The following is a description of a gene set: Mouse Gene Set: REACTOME_DNA_DOUBLE_STRAND_BREAK_REPAIR species: Mus musculus DNA Double-Strand Break Repair, and this is the list of marker genes: Pold1, Rnf4, Nsd2, Rmi2 (NCBI Gene Id 436337), Kpna2, Rfc5, Brip1, Lig4, Kdm4b, Top3a, H4c2, Babam1, Polq, Herc2, Brcc3, Eya1, Firrm, H2bc9, Lig3, Rad51b, Spidr, H2bc14, Rpa1, Xrcc4, Sirt6, Smarca5, Wrn, Hus1, Rad1, Xrcc2 (X-ray repair complementing defective repair in Chinese hamster cells 2), Mapk8, Eya3 (EYA transcriptional coactivator and phosphatase 3), Atrip, H2bc15, Timeless, Fignl1, Rad51ap1, Uimc1, Dna2, Abl1, Babam2, Xrcc3, Ccna2, Eme2, Rpa2, Parp2, Rad17, Ppp5c, Rad9a, Topbp1, H4c18, Uba52, Pold2, Sumo1, Pias4, Pcna, H2bc3, Exo1, Nhej1, H2bc24, H4c1, H4c14, Rfc4, Eya2, Tipin, Kpna2rt, Blm, Polk, Pole4, Pole2, Rnf168, Apbb1, Rif1, Tdp2, Ubxn1 (NCBI Gene Id 98173), Ccna1, H4c9, H2bc7, Ercc4, H4c4, H4c17, Ube2i, H2bc13, Brca1, H2bc11, Nbn, H2bc8 (NCBI Gene Id 319181), Rnf8, H2bc26, Ube2v2, Brca2, Tdp1, Mre11a, Rad9b, H2bc21, H4c8, H2bc12, Ubc, Gen1, H4c6, Kat5, Ubb, Rfc2, H4c3, Pold3, Pole3, Prkdc, Rad52, H2bc22, Atm, Poll, Chek1, H2ax, Fen1, Rad50, H4c16, H2bc1, Mus81, Slx4, Clspn, Eya4, Rhno1, Rfc3, Rad51d, Polm, Bard1, Rpa3, Palb2, Trp53, Cdk2, Chek2, Trp53bp1, Ppp4r2, Rmi1, H4c12, Kdm4a, H4c11, Sumo2, Uba52rt (ubiquitin A-52 residue ribosomal protein fusion product 1, retrotransposed), Xrcc1, Slx1b, H2bc23, H3f4, H2bc4, Polh, Rfc1 (replication factor C (activator 1) 1), Paxip1, Rad51, Dclre1c (DNA cross-link repair 1C), H2bc6, Mdc1, Pole, Rbbp8, Xrcc6, Xrcc5, Baz1b, Pold4, Bap1, Ercc1, Rad51c, Eme1, Ppp4c, Abraxas1, Ube2n, Rps27a, Parp1